Given this list of marker genes OPRK1, GNRH1, EGR1, NCOR2, PCNA, ADNP, SLC26A6 (NCBI Gene Id 65010), CA12, NCOA1, HAS2, PTN, MDK, here is a description of the gene set: A type of ovulation cycle, which occurs in most mammalian therian females, where the endometrium is resorbed if pregnancy does not occur. species: Homo sapiens Human Gene Set: GOBP_ESTROUS_CYCLE